Given this list of marker genes TMEM107, B9D1, COX7B, CENPF, FIG4, TMEM237, PAX6, RPGRIP1, LETM1, FOXE3, NDUFB11, NELFA, PXDN, TXNDC15 (NCBI Gene Id 79770), MAB21L2, BMP4, CPLX1, KERA, PRDM5, SIX6, PIGG, CC2D2A, HMX1, NDP, SOX2, MAPKAPK5, CEP290, TMEM216, CTBP1, RAX, TCTN1, TBX1, FGFR1, DHCR7, SLC25A24, B9D2, SCARF2, TENM3, TCTN3, TMEM231, HCCS, TMEM67, MKS1 (MKS transition zone complex subunit 1), NSD2, TCTN2, RPGRIP1L, VAC14, B3GALT6, CSPP1, here is a description of the gene set: Human Gene Set: HP_SCLEROCORNEA Sclerocornea studied in species Homo sapiens A congenital anomaly in which a part or the whole of the cornea acquires the characteristics of sclera, resulting in clouding of the cornea.